Given this list of marker genes Tspo, Snap23, Lgmn, Dynll1, Stard3, Bag1, here is a description of the gene set: Mouse Gene Set: CUI_CDC2_EGF_RESPONSE_UP from publication Cui A, Huang T, Li S, Ma A, Pérez JL, Sander C, Keskin DB, Wu CJ, Fraenkel E, Hacohen N (PMID 38057668) Cytokines mediate cell-cell communication in the immune system and represent important therapeutic targets. A myriad of studies have highlighted their central role in immune function, yet we lack a global view of the cellular responses of each immune cell type to each cytokine. To address this gap, the authors created the Immune Dictionary, a compendium of single-cell transcriptomic profiles of more than 17 immune cell types in response to each of 86 cytokines (>1,400 cytokine-cell type combinations) in mouse lymph nodes in vivo. A cytokine-centric view of the dictionary revealed that most cytokines induce highly cell-type-specific responses. For example, the inflammatory cytokine interleukin-1β induces distinct gene programmes in almost every cell type. A cell-type-centric view of the dictionary identified more than 66 cytokine-driven cellular polarization states across immune cell types, including previously uncharacterized states such as an interleukin-18-induced polyfunctional natural killer cell state. Genes positively differentially expressed in cell type: cDC2 (conventional dendritic cell type 2) upon treatment with cytokine: EGF in mouse lymph nodes in vivo. studied in species Mus musculus